The following is a description of a gene set: Any process that modulates the frequency, rate or extent of enzymatic generation of superoxide by a cell. Mouse Gene Set: GOBP_REGULATION_OF_SUPEROXIDE_ANION_GENERATION species: Mus musculus, and this is the list of marker genes: Gnai3, F2rl1, Gstp1, Itgb2, Cxcl1, Pon3, Akt1, Syk, Prkcd, App, Clec7a, Nox1, Itgb2l, Il18 (NCBI Gene Id 16173), Egfr, Fpr2, Agt, Tgfb1, Crp, Cd177, Acp5, Gnai2, Mapt, Elavl1, Itgam, Tyrobp (NCBI Gene Id 22177, TYRO protein tyrosine kinase binding protein), Cyba, Hvcn1, Agtr1a, Sod1